The following is a description of a gene set: Binds to and increases the activity of a deubiquitinase. Mouse Gene Set: GOMF_DEUBIQUITINASE_ACTIVATOR_ACTIVITY species: Mus musculus, and this is the list of marker genes: Tank, Wdr20, Wdr48, Dmwd, Tifab (TRAF-interacting protein with forkhead-associated domain, family member B), Wdr20rt, Tgfb1, Vcp